The following is a description of a gene set: studied in species Homo sapiens Human Gene Set: GOCC_EUKARYOTIC_48S_PREINITIATION_COMPLEX The protein-ribosome-tRNA complex that has just recognized the start codon of a capped mRNA. It is composed of the small ribosomal subunit, eukaryote initiation factors (eIF) eIF3 complex, eIF1, eIF1A, eIF2-GDP, eIF4 complex and initiatior-methionine-tRNA. Recognition of the start codon triggers downstream steps in the pathway, including eIF1 dissociation; Pi release from eIF2; and conversion to the closed, scanning-arrested conformation of the PIC., and this is the list of marker genes: EIF2S1, EIF3D, EIF3CL, EIF3I, EIF3B, EIF3J, EIF3M, EIF3A, EIF3L, EIF1AX, EIF3K, EIF3C, EIF3F, EIF3E, EIF3H, EIF1, EIF3G